The following is a description of a gene set: Reactome Pathway: Pyrimidine biosynthesis studied in species Homo sapiens part of: Nucleotide biosynthesis The pyrimidine orotate (orotic acid) is synthesized in a sequence of four reactions, deriving its atoms from glutamine, bicarbonate, and aspartate. A single multifunctional cytosolic enzyme catalyzes the first three of these reactions, while the last one is catalyzed by an enzyme associated with the inner mitochondrial membrane. In two further reactions, catalyzed by a bifunctional cytosolic enzyme, orotate reacts with 1-phosphoribosyl 5-pyrophosphate (PRPP) to yield orotidine 5'-monophosphate, which is decarboxylated to yield uridine 5'-monophosphate (UMP). While several individual reactions in this pathway are reversible, other irreversible reactions drive the pathway in the direction of UMP biosynthesis in the normal cell. All reactions are thus annotated here only in the forward direction.<P>This pathway has been most extensively analyzed at the genetic and biochemical level in hamster cell lines. All three enzymes have also been purified from human sources, however, and the key features of these reactions have been confirmed from studies of this human material.<p>All other pyrimidines are synthesized from UMP. The reactions annotaed here, catalyzed by dCMP deaminase and dUTP diphosphatase yield dUMP, which in turn is converted to TMP by thymidylate synthase., and this is the list of marker genes: DHODH, CAD, UMPS